The following is a description of a gene set: Mouse Gene Set: GOBP_REGULATION_OF_TWITCH_SKELETAL_MUSCLE_CONTRACTION Any process that modulates the frequency, rate or extent of twitch skeletal muscle contraction. species: Mus musculus, and this is the list of marker genes: Strit1, Mylk2, Atp2a1, Actn3, Myh7